The following is a description of a gene set: An abnormality of the cerebrospinal fluid (CSF). Human Gene Set: HP_ABNORMAL_CEREBROSPINAL_FLUID_MORPHOLOGY Abnormal cerebrospinal fluid morphology species: Homo sapiens, and this is the list of marker genes: SUFU, POMGNT2, PHYH, GLYCTK, KANSL1, AMT, AKT1, MPV17, EGR2, TTC12, ZNF423, PTCH1 (NCBI Gene Id 8015), LMNB2, NOTCH3, STAG2, RSPO2, COX20 (cytochrome c oxidase assembly factor COX20), POMT2, HES7, MT-ATP6, BCKDK, CEP104, CDC42BPB, TIMMDC1, DNM1L, TLR3, CDC40, ODAD4, IFT172, ZIC2, PNPO, LYRM7, ERCC6, UBAP1, MKS1 (NCBI Gene Id 54903), ZBTB20, HPDL, NME8, DPYSL5, SPIN4, CEP120, COG6, SCN1A, CENPF, SLC17A5, NDUFS1, UFD1 (NCBI Gene Id 7353), OGDH, FAM20C, MT-TS2, NDUFS3, PDE6D, SLC25A24, RPGRIP1, UNC13D, SUCLA2, TMEM107, TOE1, TCOF1, TSEN15, DARS2, SURF1, DHCR24, TCIRG1, SEC24C, STAT2, NUP214, CTNNA2, EIF2B5, IFNG, NEU1, SPEF2, SMOC1, NDUFV2 (NCBI Gene Id 4729), NDUFA12, SHOC2, B4GAT1, POMGNT1, RNASEH2C, SHH (sonic hedgehog signaling molecule), ODAD3, NR4A2, COL4A1, SAMD9, EOGT, AP1S2, FBXL4, MT-ND2, TRAPPC12, NKX3-2, MUSK, PET100, COX11, CACNA1A, NDUFA11, COQ8A, RNU4-2, CDCA7, COPB2, PTDSS1, OSTM1, GFAP, NDUFS7, ARL13B, POLG, PTS, BTNL2, ALG13, RANBP2, DCC, MT-TH, DLG5, TOGARAM1, IBA57 (NCBI Gene Id 200205), RREB1, ASPA, PTPN22, PIEZO2, HMBS, CPT2, MT-ND3 (mitochondrially encoded NADH:ubiquinone oxidoreductase core subunit 3), IFT43, VANGL1, TBC1D7, TTR, MCIDAS, FANCG, TAOK1, AIFM1, TSPOAP1, RTN2, ZNHIT3, SEC24D, PEX12, NAXE, MTM1, KIAA0753, NDUFV1 (NCBI Gene Id 4723), DRC1, EML1, MAF, IRF3, PRX, VSX1, RASA1, MRPS34, TMEM222, COX10, LSM11, NFIX, LARGE1, SUMF1, CFAP221, VPS35L, WDR81, KRAS, COX4I1, PDGFB, ERCC5, SAMHD1 (NCBI Gene Id 25939), MT-TV, FARS2, CC2D2A, CBY1, FIG4, GLI2, SOX2, BOLA3, MPZ, POLR3A, TMEM126B, RSPH9, SLC25A1, TAF2, TPK1, CTBP1, POR, FLVCR2, UHRF1, TBK1, CCDC39, CSF1R, PYCR1, TMEM231, FGFR1, NDUFAF5, SLC31A1, MED12, NEK1, MECP2, AIP, MT-ND1, HSPG2, BRCA1, PIBF1, JMJD1C, LRRC56, CPLANE1, MT-TW, KIF7, DNAAF5, BLTP1, SLC25A4, TCTN1, ZEB2, MYT1L, MNX1, GFM2, DISP1, PDHA1, PRDX1, HERC1, NME5, ZBTB24, CCDC40, TP53, FOXJ1, VAC14, FGFR2, TRMT1, D2HGDH (NCBI Gene Id 728294), IDUA, DNAAF2, GLI3, DOCK6, FBN1 (fibrillin 1), ECHS1, NPHP1, DNAL1, KMT2D, ESCO2, HBA2, SETD2, NOTCH2, CD59, DPYS, RPGRIP1L, SLC29A3, NSD2, CASP2, FKRP, RAD51C, NDUFA6, GFM1, PIGU, DPH2, DLAT, NDUFA4, CRIPTO, TBXT, MT-TN, STX11, SMARCE1, PNPT1, KDM4B, KATNIP, NOTCH1, TH, BRAF, GUSB, RNASEH2A, CMPK2, GPC4, INPP5E, STK36, PRKAG2, UPB1, SF3B2, TSC2, MTFMT, TIMM50, ATP5PO, OFD1, RPIA, POMT1, TRPV6 (NCBI Gene Id 55503), HYDIN, GPSM2, IARS2, COL18A1, NEK10, FANCL (NCBI Gene Id 55120), ARSB, IFIH1, RNU4ATAC, ERF, MAN2B1, SOX9, NODAL, ZMYND10, AMER1, MMACHC, ESAM, HNRNPU, DLL4, RBPJ, UNC45A, ERCC8, LONP1, ATP1A2, PSAP, CEP41, SIX3, ALDH7A1, PNPLA8, KDM6A, ARSA, FGFRL1, PIGV, PLG, TRPV4, CCNO, ADK, STXBP2, HSD17B10 (NCBI Gene Id 50828), MAP2K2 (mitogen-activated protein kinase kinase 2), GAS1, MADD, CPLX1, RAD51, CFAP298, SLX4, DNAH9, COX14, ADAR, SUCLG1, TK2, STAMBP, TRNT1, RMND1, UNC93B1, FAM111A, TREX1, SALL1, EXOSC2, KIF26A, STIL, FANCD2, FGF8, TBX4, TMEM237, FANCM, KIAA0586, HLA-DQB1, FANCI, PALB2, MT-CO3 (mitochondrially encoded cytochrome c oxidase III), GPR101, HDAC6, RAF1, TRAF7, FOXRED1, IFT56, SPAG1, DNAAF6, POMK, RNU7-1, IMPDH2, SLC13A3, GMPPB, B3GAT3, FGFR3, MICU1, CCDC22, NARS2, GCH1, TREM2, TUBB3, LAMB1, OPA1, SLC13A5, TBX1, RNASEH2B, DLL1, TXN2, SLC12A2, RXYLT1, CCND2, MT-TQ, BICRA, MT-ATP8, HLA-DRB1, RRM2B, TERT, TMEM67, NDUFB3, EBP, MT-ND4, ROBO1, IDS, DNAAF4, HRAS, CLCN7, CTNNB1, CDON, SLC12A6, PPIL1, TRAF3, NDUFB11, NDUFAF4, GPC3, MT-TL1, PIK3CA, L1CAM, NDUFAF8, ARHGAP31, USP7, TCTN3, ROGDI, TMEM216, TRIM71, MT-TK, NDUFS8, MDH2, BCAT2, MPDZ, ALK, LYRM4, PET117, FTL, BAP1 (BRCA1 associated deubiquitinase 1), ASL, SIK3, H4C9, NGLY1, NDUFAF3, AHDC1, DNAH1, ODAD1, SMARCB1, NDUFS2, RPGR, ALDH4A1, HELLS, DHFR, SLC33A1, SMO, ATPAF2, PIGA, CYP27A1, SCN4A, FTO, NRAS, CYP26C1, GBE1, GLRX5 (NCBI Gene Id 51218), WASHC5, TRMT10C, CILK1 (NCBI Gene Id 51541), CCDC88C, BRIP1 (BRCA1 interacting helicase 1), ARL3, TNFRSF11A, GALC, PRF1, PTCH2, NDUFS4, OCLN, DLD, IRF4, GCSH, CPT1C, LETM1, PAK3, FKTN, DNAH11, SMARCC1, CLCN3, UQCC2, P4HB (prolyl 4-hydroxylase subunit beta), NF2, VPS33A, PIK3R2, GNAQ, NDUFB8, BICD2, TBCK, FANCC, GRIK2, NDUFB10, RECQL4, LRPPRC, PRRT2, FANCE, FLNA, DENND5A, TGFBR1, NDUFA10, HTRA2, SNX10, ANKH, CEBPE, PSAT1, PEX19, TXNDC15, PPP1CB, TYROBP, NRCAM, NDUFA8, HCCS, SLC25A19, RSPH4A, PRKAR1A, NOTCH2NLC, MFN2, SPTBN1, XRCC2, NDUFAF1, VAMP1, DAG1, MT-ND6, PPP2R1A, LIG4 (NCBI Gene Id 3981), GAS2L2, CHST3, TICAM1, DPH1, DNAI1, NDUFS6, CEP290, EPHB4, VANGL2, PLCH1, DNAJB13, B9D2, B9D1, PPP1R21, MT-CO2, GRIP1, HYLS1, PORCN, B4GALT1, DHCR7, NF1, PAK2, RSPH1, DNMT1 (NCBI Gene Id 1786), NADK2, AASS, TYMP, TGFBR2, WNT3, GLUL, MTRR, RARS2, CSPP1, SKI, LIG3, ALDH5A1 (NCBI Gene Id 7915), KARS1, NUBPL, DNAI2, RNF125, IGHG2, NDUFB9, MAP2K1, ERCC4, TET3, MT-ND5, CFAP43, B3GALT6, LMNB1, MT-TF, MTHFR, TMEM218, COX8A, CLPB, LMBR1, NFU1, COX6B1, POLR1A, SCO2 (synthesis of cytochrome C oxidase 2), BRCA2, HBA1, B3GLCT, PEX7, RSPH3, NDUFA1, FAS, IFT74, DNAAF1, SLC39A8, AHI1, TGIF1, GP1BB, FRAS1, CRB2, NDUFAF2, CEP83, TNFSF11, ABHD5, PSMB9, DNMT3B, PRNP, FUZ, TBX15, CFAP300, PMP22, MT-CYB, ZPR1, B3GALNT2, BUB1B, FANCF, MAD2L2, CRTAP, IGKC, NSUN2, AKT3, COMT, SLC32A1, RFWD3, MYCN, MT-CO1, UBE2T, COX7B, FOXH1, TSC1, CCL2, UQCC3, TCTN2, ERCC3, SMC1A, SLC2A1, GBA1, SLC6A3, FANCA, ARMC9, CRPPA, KPNA3, DDC, COA8, ZIC3, MBTPS2, DNAH5 (NCBI Gene Id 64774), GCDH, CFAP74, TMEM138, HIRA, DNAAF3, PPP2R5D, ODAD2, PTEN, ERCC2, FANCB, ACBD6, RAC3, DNAAF11, SF3B4, PDHX, SOX5, ARVCF